The following is a description of a gene set: Human Gene Set: REACTOME_BIOSYNTHESIS_OF_MARESINS species: Homo sapiens Biosynthesis of maresins, and this is the list of marker genes: CYP1A2, CYP2E1, CYP2C9, CYP2D6, ALOX5, CYP3A4, EPHX2, CYP2C8